The following is a description of a gene set: Human Gene Set: GOBP_NUCLEOSIDE_CATABOLIC_PROCESS studied in species Homo sapiens The chemical reactions and pathways resulting in the breakdown of any one of a family of organic molecules consisting of a purine or pyrimidine base covalently bonded to a sugar ribose (a ribonucleoside) or deoxyribose (a deoxyribonucleoside)., and this is the list of marker genes: DPYD, MTAP, AICDA, ADA, PNP, NUDT1, UPB1, DERA, UPP1, APOBEC3C, CDA, ADA2, UPP2, XDH, APOBEC3G, ENPP4, CDADC1, DCTD, MAPDA, GDA